The following is a description of a gene set: TGFBR3 regulates TGF-beta signaling Human Gene Set: REACTOME_TGFBR3_REGULATES_TGF_BETA_SIGNALING studied in species Homo sapiens, and this is the list of marker genes: ARRB2, TGFB1, ARRB1, TGFBR2, TGFBR3, TGFBR1, GIPC1, TGFB2